The following is a description of a gene set: Human Gene Set: REACTOME_EGFR_DOWNREGULATION EGFR downregulation studied in species Homo sapiens, and this is the list of marker genes: UBC, SPRY1, ARHGEF7, SPRY2, CDC42, STAM2, HBEGF, EPS15, PTPN12, CBL, STAM, PTPN3, EGF, SH3GL3, UBB, GRB2, SH3GL1 (SH3 domain containing GRB2 like 1, endophilin A2), UBA52, HGS, EGFR, EPN1, EPS15L1, EPGN, SH3GL2, AREG, SH3KBP1, TGFA, BTC, EREG, PTPRK, RPS27A